The following is a description of a gene set: Unfolded and malfolded client proteins impose a stress on the endoplasmic reticulum (ER), which contributes to cell death in pathophysiological conditions. The transcription factor C/EBP homologous protein (CHOP) is activated by ER stress, and CHOP deletion protects against its lethal consequences. We find that CHOP directly activates GADD34, which promotes ER client protein biosynthesis by dephosphorylating phospho-Ser 51 of the alpha-subunit of translation initiation factor 2 (eIF2alpha) in stressed cells. Thus, impaired GADD34 expression reduces client protein load and ER stress in CHOP(-/-) cells exposed to perturbations that impair ER function. CHOP(-/-) and GADD34 mutant cells accumulate less high molecular weight protein complexes in their stressed ER than wild-type cells. Furthermore, mice lacking GADD34-directed eIF2alpha dephosphorylation, like CHOP(-/-) mice, are resistant to renal toxicity of the ER stress-inducing drug tunicamycin. CHOP also activates ERO1alpha, which encodes an ER oxidase. Consequently, the ER of stressed CHOP(-/-) cells is relatively hypo-oxidizing. Pharmacological and genetic manipulations that promote a hypo-oxidizing ER reduce abnormal high molecular weight protein complexes in the stressed ER and protect from the lethal consequences of ER stress. CHOP deletion thus protects cells from ER stress by decreasing ER client protein load and changing redox conditions within the organelle. from publication Marciniak SJ, Yun CY, Oyadomari S, Novoa I, Zhang Y, Jungreis R, Nagata K, Harding HP, Ron D (PMID 15601821) Endoplasmic retuculum (ER) stress response (caused by tunicamycin) genes dependent on CHOP. Mouse Gene Set: MARCINIAK_ER_STRESS_RESPONSE_VIA_CHOP studied in species Mus musculus, and this is the list of marker genes: Ero1a, Cdca7, Soat2, Wfs1, Car6, Chka, Stbd1, Lonp1, Ddit3, Mtm1, Rad1, Adh7, Ets2, Kitl, Ptrh2, Ifi202b, Ptx3, Clcn3, Polr1a, Ppan, Ppp1r15a, Ampd3, Pard6a